The following is a description of a gene set: Genes down-regulated in bone marrow-derived macrophage (45 min): LPS versus IL6 and LPS. Human Gene Set: GSE5589_LPS_VS_LPS_AND_IL6_STIM_MACROPHAGE_45MIN_DN species: Homo sapiens IL-10 or IL-6 stimulation of control 129xC57BL/6 murine bone marrow derived macrophages in the presence of LPS. We used microarrays to detail the global programme of gene expression changes in response to IL-6 or IL-10 stimulation in the presence of lipopolysaccharide. BMDMs were isolated from control, IL-6-/-, and IL-10-/- mice on a 129XBL/6 mixed background mice and differentiated in the presence of CSF-1 for 6-7 days. Cells were scraped and plated in 6 well plates at 2x10e6/well. Cells were washed with complete DMEM and rested for 1-2 hr before stimulation with combinations of IL-10 (10 ng/ml), IL-6 (2 ng/ml) or LPS (100 ng/ml) for 45 min or 180 mins. Complete biological replicates were performed. from publication El Kasmi KC, Holst J, Coffre M, Mielke L, de Pauw A, Lhocine N, Smith AM, Rutschman R, Kaushal D, Shen Y, Suda T, Donnelly RP, Myers MG Jr, Alexander W, Vignali DA, Watowich SS, Ernst M, Hilton DJ, Murray PJ (PMID 17114459), and this is the list of marker genes: COX6A1, SOAT2, DLD, STIP1, CDKN2B, EIF2B2, SMARCAD1, COX6A2, ELOVL5, NAP1L4, ATP8A2, MRPL1, PWP2, EIF3G, RAD23B, SMURF1 (NCBI Gene Id 730332), PLPP3, MRPS18B, SLC25A51, EIF3B, ACOT11, RIOX2, DLL3, MECR, AK3, ORMDL2, HK3, RIMS3, SRSF7, KMT5A, PPP4R3B, SCAMP3, ANXA7, PPT2, PDE3B, APEX1, QNG1, MARS1, KTI12, PSME3, TBRG4, FFAR2, ANGPTL3, BAZ2B, GSKIP (NCBI Gene Id 51527), CHMP1B, GFM1, KIF5B, CDC34, BRS3, UTP18, TCERG1, AGPAT4, ECE2, PUM3, WDR12, TUBB4A, SAP18, IL1A, CMPK1, GRWD1, INTS9 (NCBI Gene Id 55756), SMG5, ZSWIM1, AIMP2, PKDCC, FUBP1, SLC7A1, CAPN1, GAR1 (NCBI Gene Id 54433), C1GALT1C1, M6PR, PRKAA1, ATP7A, DYNC1LI1, VKORC1L1, MMGT1, EXOSC2, PDHA1, MAFF, ESF1, TAX1BP3, MIEF1, KCNAB1, UGDH, H3C4, SARS1, PTPN3, GLRX2, SCLY, ITGB3, KAT14, TAGLN2, OTUD6B, RNH1, VWA8, MCRIP2, PLK3, EBAG9, UBE2M, GYPC, PECAM1, GSTO1, TSPAN14, GTF2H3, SLC27A1, ILF2, SMYD5, LTA4H, AATF, SGTB, EPOR, HAT1, HMG20B, CTU2, ELL2 (elongation factor for RNA polymerase II 2), TOR2A (torsin family 2 member A), CDYL, CIAO2A, TNK2, GALNT1, WDR75, PPP1R7, TOMM70, ETV3, CITED4, CCDC59, PRKCA, SEMA6A, LRRC20, MGAT4B, RCC1, PCBD2, CMAS, SLC4A2, YME1L1, TMT1A, PCYT1A, SNRPB, PLIN3, GMPR, ADRM1, CTRC, TEX30, DNAJA3, ENOPH1, RPRD2, FMC1, VPS33B, ZNF697, STARD3, KLHL9, ANKRD37, MRPL17, NKRF, DYNLL1, ARHGAP39, PTK2, GTPBP4, ETFDH, STUB1, CSRNP1, COMTD1, DGKE, RIPK3, RETSAT, PDE5A, ACOT9, CNOT11, VAMP4, NSUN2, PPP2R2A, EIF2S1, MRPL40, HSD3B7, DHX15, EMC4, CYC1, ZPR1, STRAP, CAMK2N1, CLIC4, ACOX1, ANGPTL4, LARP4B, IFI30, WRNIP1, PDE6D (NCBI Gene Id 5147), ENPP6, TARBP2, WDR77 (WD repeat domain 77), ATP6V1H, PDE12, SIGMAR1, SLC39A6, IL17RC, DTWD1, ARL14EP, ERO1A (endoplasmic reticulum oxidoreductase 1 alpha)